Given this list of marker genes PBX2, GDAP2, ANP32A, RBL1, ZFP30 (ZFP30 zinc finger protein), PHF13, MBLAC2 (metallo-beta-lactamase domain containing 2), INTS6, RELA, ABCG1, TIRAP, DHX36, TRIM68, FEM1B, GTF2A1, ULK1, SCAF11, KMT2D (NCBI Gene Id 8085), GABPB1, BRD3OS, DPH2 (NCBI Gene Id 1802), TMUB1, TAAR9, CLEC2B, TLCD3A, METTL21A, CAMTA2, IFT70A, ZMYM2, PDK1, UFM1, UFL1, RGS13, HOXD-AS2, ZNF395, H3C2, FUS, SDK1, TWNK, NKTR, PADI4, RCE1, HGS, IER2, PRDM11, LINC00472, RNF185, APH1A, TEX9, LINC00852, CCL4, DNAJC11, EIF3A, DYNLL2, UTS2, SF3B2, GGNBP2, ROBO2, LINC00265, CSRNP1, MCUB, API5, GPATCH4, TPR, SMAD4, NMRK2, BNIP3L, UTP20, GRID1-AS1, MALAT1, COIL, RFFL, GFOD1, ZNF800, TMEM185B, PTK2B, MIR124-2HG, WDTC1, GATAD2B, S1PR2, ZNF717, GNL3LP1, PIANP, GGACT, RAB36, FOS, SNORA28, AHCTF1, CCDC186, SRGAP2 (SLIT-ROBO Rho GTPase activating protein 2), TSPAN11, GBP2, PATL1, YEATS4, AP2A1, ZNF12, SERPINB1, DPPA5P4, FRG2EP, NPEPPS, H3C7, USP36, ALG10B, CIDEC, MRPS30, KDM4C, SLC25A43, CUL7, RNF220, PCIF1, KIF2A, SP2-AS1, UBQLN1, HDAC7, NUMB, ZNF292, ZXDC, CNPPD1, TAGLN2, DSTYK, SCAF8, CHRNE, CPB2, TPM3P4, APPBP2, CFAP221, WDR49, DNMT3A, DCAF10, NELFA, POU3F3, ZNF620, ANKRD17, FBXO46, IPO13, TNIP1, MCM7, TMEM128, PHACTR2-AS1, OR7E19P, MRPS9, TMEM214, PLAT, VAC14, ZNF512B, SF3B1, TIGD1, MID1IP1, RAB7A, RIF1, IL12RB2, CBLB, ZNF37BP, TAF6, RMND5A, SLC25A31 (NCBI Gene Id 83447), SNTB1, NUP160, DPP10, IPO4, TLNRD1, SLC46A1, ARHGEF1, RPL39, AK4, ATG14, AP4E1, QTRT2, OSBPL8, PCDHGB5, VEGFA, AP1AR, DHX34, NUDCD3, SLC22A4, FYN, NFKB2, DENND4A, RNF115, KCTD10, C1QTNF7, GOLGA2, CYB5D2, WDR11, DRAXIN, CBLN2, WIPF2, MUSTN1, RAB14, LCTL, here is a description of the gene set: Genes down-regulated in HMC-1 (mast leukemia) cells: Cl-IB-MECA versus T cell membranes. from publication Baram D, Dekel O, Mekori YA, Sagi-Eisenberg R (PMID 20190146) Human Gene Set: GSE19888_ADENOSINE_A3R_ACT_VS_TCELL_MEMBRANES_ACT_IN_MAST_CELL_DN We demonstrate that the G protein Gi3 is the cellular target of the adenosine A3 receptor (A3R). By using a cell permeable peptide comprising the C-terminal end of Gαi3 fused to an importation sequence (ALL1) as a selective inhibitor of Gi3 signaling, we show that by coupling to Gi3, the A3R stimulates multiple signaling pathways in human mast cells, leading to upregulation of cytokines, chemokines and growth factors.Following contact with activated T cell membranes, endogenous adenosine binds to and activates the A3R, resulting in Gi3-mediated signaling. Specifically, the majority of ERK1/2 signaling initiated by contact with activated T cell membranes, is mediated by Gi3, giving rise to ALL1-inhibitable cellular responses. These results unveil the physiological GPCR that couples to Gi3 and establish the important role played by this G-protein in inflammatory conditions that involve adenosine-activated mast cells. We used microarrays to detail the effect of ALL1 on gene expression of HMC-1 cells activated directly by the A3 receptor, or by contact with activated T cell membranes. species: Homo sapiens